The following is a description of a gene set: Human Gene Set: GOBP_NEGATIVE_REGULATION_OF_HAIR_FOLLICLE_DEVELOPMENT studied in species Homo sapiens Any process that stops, prevents, or reduces the frequency, rate or extent of hair follicle development., and this is the list of marker genes: FERMT1, CDH3, NGFR, SMO, DKK4